Given this list of marker genes DIO2, SELENOF, GPX3, RPH3A, DIO1, SELENOP, SELENBP1, GPX4, SELENOT, here is a description of the gene set: Binding to a selenium (Se) ion. Human Gene Set: GOMF_SELENIUM_BINDING studied in species Homo sapiens